The following is a description of a gene set: species: Mus musculus Mouse Gene Set: GOBP_POSITIVE_REGULATION_OF_ESTABLISHMENT_OF_PROTEIN_LOCALIZATION_TO_TELOMERE Any process that activates or increases the frequency, rate or extent of establishment of protein localization to telomere., and this is the list of marker genes: Cct2, Tcp1, Cct8, Dkc1, Wrap53, Cct5, Cct4, Cct7, Cct3, Cct6a